Given this list of marker genes CCDC38, ACSL1, ST6GALNAC2, ANO4, LINC01019, ST20-AS1, BOD1L2, SOWAHC, RNF148, LSM10, FAM89A, SLC39A12, C14orf93, HEXB, KRTAP4-3, PEPD (peptidase D), PHLDB2, HHIP, TEX14, GDPD1, UBB, OR10A5, PON3, HADH (hydroxyacyl-CoA dehydrogenase), ALB, PPP1R14D, OSBPL6, OAS1, DNER, AGAP2-AS1, ALG9, NAA20, UNC5CL, EPAS1, ADAMTS15, UBXN11, GGA2, LMAN2L, LINC00842, PTPDC1, PIERCE2 (piercer of microtubule wall 2), PHACTR1 (phosphatase and actin regulator 1), SPINK1 (serine peptidase inhibitor Kazal type 1), TCERG1L, AMIGO2, DNAJC6, KLHL9 (kelch like family member 9), ABHD6, SCARB1, CXorf51A, PIP4K2A, CRIM1, MAGEA5P, SEMA4B, ABHD5, TTC39B, PRAM1, IRS2, DOCK11, PRL, ARHGAP11A, SVIL, SAYSD1 (SAYSVFN motif domain containing 1), TLCD2, PCCA, DBNDD1, TTC9, CNST, PPP5D1P, EAF2, KCNQ3, RPP25, ADAM17, DEFB1, NDUFB3, PDC, GPRASP1, TERB2, DNAJB11, GYPA, AIFM2, CD68, RHCE, SPINK2, PGBD5, KCNE1, DISP1, CABLES1 (Cdk5 and Abl enzyme substrate 1), STAU2, PRM3, CAPN6, PCOLCE2, KIRREL3, FOXF2, KRT6B, APOL6, SYDE2, SIPA1L2, VLDLR, MYO5C, TMEM80, DBI (NCBI Gene Id 1622), WDFY3-AS2, SLC34A2, TRIB2, THRSP, DTX4, HENMT1, ZIM2, MIR99AHG, TUG1, MCEMP1, CD82, GPR107, NAV2-AS5, HSD11B1, ME3, CRLS1, RNASEL, ZFP37, HERC5, IL7R, KIF20B, OLFM3, FCGRT, TSC22D1, PBK, SCCPDH, CNTFR-AS1, POR, SHANK3, CASC22, AATBC, CCDC138, AGPAT4 (NCBI Gene Id 56895), NUP214, KLHL34, PURPL, PCDHB4, RARRES1, DTWD1, UIMC1, TCTN2, CD2, PRDM15, OTOGL, PARP9, LACTB2, WASF1, NEUROG3, EFHC2, GPRIN3, PLIN2, OR51B5, APOC1, DMD, MARS2 (methionyl-tRNA synthetase 2, mitochondrial), IFNK, MMP19, FGF19, STK32B, CFDP1, PNLIPRP3, TMEM11, BST1, TMEM237, TMEM53, ENG, PRKCB, SLC22A2, IRF7, ZNF300, CYP4F22, LPCAT3, TAS2R16, RPP38, ZNF280A, IFIT2, CASTOR3P, BLVRB, AHI1, SCARNA15, STAT3, LPXN, NANS, NXPE3, TBC1D2, CORO2A, TIGD2, IL1F10 (interleukin 1 family member 10), OR5AK4P, S100A8, LINC00624, OR6A2, CCZ1, here is a description of the gene set: Genes down-regulated in CD4 Th1 cells: wildtype versus EGR2 knockout. T cell anergy is one of the mechanisms contributing to peripheral tolerance, particularly in the context of progressively growing tumors and in tolerogenic treatments promoting allograft acceptance. We recently reported that early growth response gene 2 (Egr2) is a critical transcription factor for the induction of anergy in vitro and in vivo, which was identified based on its ability to regulate the expression of inhibitory signaling molecules diacylglycerol kinase (DGK)-a and -z. We reasoned that other transcriptional targets of Egr2 might encode additional factors important for T cell anergy and immune regulation. Thus, we conducted two sets of genome-wide screens: gene expression profiling of wild type versus Egr2-deleted T cells treated under anergizing conditions, and a ChIP-Seq analysis to identify genes that bind Egr2 in anergic cells. Merging of these data sets revealed 49 targets that are directly regulated by Egr2. Among these are inhibitory signaling molecules previously reported to contribute to T cell anergy, but unexpectedly, also cell surface molecules and secreted factors, including lymphocyte-activation gene 3 (Lag3), Class-I-MHC-restricted T cell associated molecule (Crtam), Semaphorin 7A (Sema7A), and chemokine CCL1. These observations suggest that anergic T cells might not simply be functionally inert, and may have additional functional properties oriented towards other cellular components of the immune system. Human Gene Set: GSE46242_CTRL_VS_EGR2_DELETED_TH1_CD4_TCELL_DN from publication Zheng Y, Zha Y, Spaapen RM, Mathew R, Barr K, Bendelac A, Gajewski TF (PMID 23548837) studied in species Homo sapiens